The following is a description of a gene set: Any process that modulates the frequency, rate or extent of termination of RNA polymerase II transcription, poly(A)-coupled. Human Gene Set: GOBP_REGULATION_OF_TERMINATION_OF_RNA_POLYMERASE_II_TRANSCRIPTION_POLY_A_COUPLED studied in species Homo sapiens, and this is the list of marker genes: SETX, PPP1CA, SCAF8, PPP1R10, SCAF4